Given this list of marker genes BMPR2, TBX5, SMO, TGFB2, ZFPM1, TBX20, CCN1, NOTCH2, HEY2, NSD2, ACVR1, ISL1 (ISL LIM homeobox 1), GJA5, GATA4, NKX2-5, SOX4, here is a description of the gene set: Human Gene Set: GOBP_ATRIAL_SEPTUM_MORPHOGENESIS The developmental process in which atrial septum is generated and organized. The atrial septum separates the upper chambers (the atria) of the heart from one another. species: Homo sapiens